Given this list of marker genes Spam1, Cemip, Cemip2, Hyal1, Hyal5, Hyal2, Hyal4, Hyal3, here is a description of the gene set: Catalysis of the random hydrolysis of (1->4) linkages between N-acetyl-beta-D-glucosamine and D-glucuronate residues in hyaluronate. studied in species Mus musculus Mouse Gene Set: GOMF_HYALURONONGLUCOSAMINIDASE_ACTIVITY